Given this list of marker genes Sirt2, Ccnb1-ps, Ncaph2, Ncaph, Cenpe (centromere protein E), Numa1, Kat2b, Kat5, Aurkb, Rad18, Smc2, Birc5, Hnrnpu, Ncapd3, Smc6, Ska3, Cdca8, Ccnb1, Mad1l1, Rcc2, Ncapg2, Becn1, Prap1, Cdc6, Mad2l1bp, Incenp, Ncapd2 (non-SMC condensin I complex, subunit D2), Smc5, Cdk1, Ska1, Smc4, here is a description of the gene set: Mouse Gene Set: GOBP_POSITIVE_REGULATION_OF_CHROMOSOME_SEGREGATION Any process that activates or increases the frequency, rate or extent of chromosome segregation, the process in which genetic material, in the form of chromosomes, is organized and then physically separated and apportioned to two or more sets. species: Mus musculus